Given this list of marker genes NOXA1, APOA4 (apolipoprotein A4), HBG2, FYN, DUOX2, EPX, DUOX1, PRDX1, ACOX1, HBE1 (hemoglobin subunit epsilon 1), TXN, SOD2, HP, GPX1, MPO, HBZ, MAOB (monoamine oxidase B), CYBB, HDAC6 (histone deacetylase 6), CYBA, PINK1, NOXO1, PRDX5, GPX3, MPV17L, CYP1A1, RAC1, HBG1, SNCA, PRDX2, HBM, TPO (thyroid peroxidase), HBQ1, PRDX6, PXDNL (peroxidasin like), NNT, MT3, LPO, CAT (catalase), PRDX4, ZNF205, DUOXA2, HBB, NOX1, HBA1, STAT3, RAC2, SOD1, PRDX3, CYP1A2, HBD, NCF1, DUOXA1, PXDN, PARK7, HBA2, here is a description of the gene set: The chemical reactions and pathways involving hydrogen peroxide (H2O2), a potentially harmful byproduct of aerobic cellular respiration which can cause damage to DNA. Human Gene Set: GOBP_HYDROGEN_PEROXIDE_METABOLIC_PROCESS species: Homo sapiens